The following is a description of a gene set: Mouse Gene Set: GOMF_ATPASE_INHIBITOR_ACTIVITY studied in species Mus musculus Binds to and stops, prevents or reduces an ATP hydrolysis activity., and this is the list of marker genes: Atp5if1, Tsc1, Fnip2, Fnip1, Agrn, Pln